Given this list of marker genes HADH, GABRA2, TNFRSF11B (NCBI Gene Id 4982), STXBP2, GPR37, MED1, SLC30A3, TRAF1, PFN1, IKBKG, PZP (NCBI Gene Id 5858), SORBS2, TSPAN4, COL9A1, RAD51, GAST, MSR1, DHX16, GTF2F1, SPRR2B, SPEG, HAGH, GOLGA2, TLE3, RGR, MDK, ACTN1, ARPC2 (actin related protein 2/3 complex subunit 2), ADRA1B, NRTN, ARTN, RIT2, ICAM5 (intercellular adhesion molecule 5), here is a description of the gene set: studied in species Homo sapiens Human Gene Set: BANDRES_RESPONSE_TO_CARMUSTIN_MGMT_24HR_DN Genes down-regulated in T98G cells (glioma, express MGMT) by carmustine at 24 h. Chemotherapy with the alkylating agent BCNU (1,3-bis (2-chloroethyl)-1-nitrosourea) is the most commonly used chemotherapeutic agent for gliomas. However, the usefulness of this agent is limited because tumor cell resistance to BCNU is frequently found in clinical brain tumor therapy. The O6-methylguanine-DNA methyltransferase protein (MGMT) reverses alkylation at the O6 position of guanine and we have reported the role of MGMT in the response of brain tumors to alkylating agents. However, the different mechanisms underlying the patterns related to MGMT remain unclear. To better understand the molecular mechanism by which BCNU exerts its effect in glioma cell lines according MGMT expression, we used microarray technology to interrogate 3800 known genes and determine the gene expression profiles altered by BCNU treatment. Our results showed that treatment with BCNU alters the expression of a diverse group of genes in a time-dependent manner. A subset of gene changes was found common in both glioma cell lines and other subset is specific of each cell line. After 24 h of BCNU treatment, up-regulation of transcription factors involved in the nucleation of both RNA polymerase II and III transcription initiation complexes was reported. Interestingly, BCNU promoted the expression of actin-dependent regulators of chromatin. Similar effects were found with higher BCNU doses in MGMT+ cell line showing a similar mechanism that in MGMT-deficient cell with standard doses. Our data suggest that human glioma cell lines treated with BCNU, independently of MGMT expression, show changes in the expression of cell cycle and survival-related genes interfering the transcription mechanisms and the chromatin regulation. from publication Bandres E, Andion E, Escalada A, Honorato B, Catalan V, Cubedo E, Cordeu L, Garcia F, Zarate R, Zabalegui N, Garcia-Foncillas J (PMID 15980968)